The following is a description of a gene set: species: Mus musculus A process, occurring in the muscle, that is characterized by a decrease in protein content, fiber diameter, force production and fatigue resistance in response to different conditions such as starvation, aging and disuse. Mouse Gene Set: GOBP_MUSCLE_ATROPHY, and this is the list of marker genes: Gatm, Asb2, Fbxo32, Tbce, Cflar, Mstn, Gsn, Ep300, Actn3, Mtor, Rps6kb1, Foxo3, Nol3, Myog